Given this list of marker genes Pole, Pold1, Trex1, Apex1, Rad1, Rexo2, Polg, Isg20, Apex2, Exd2, Mre11a, Rad9a, Tatdn1, Trex2, Meiob, here is a description of the gene set: Mouse Gene Set: GOMF_3_5_DNA_EXONUCLEASE_ACTIVITY species: Mus musculus Catalysis of the sequential cleavage of mononucleotides from a free 3' terminus of a DNA molecule.